The following is a description of a gene set: Individuals with 22q11.2 microdeletions show behavioral and cognitive deficits and are at high risk of developing schizophrenia. We analyzed an engineered mouse strain carrying a chromosomal deficiency spanning a segment syntenic to the human 22q11.2 locus. We uncovered a previously unknown alteration in the biogenesis of microRNAs (miRNAs) and identified a subset of brain miRNAs affected by the microdeletion. We provide evidence that the abnormal miRNA biogenesis emerges because of haploinsufficiency of the Dgcr8 gene, which encodes an RNA-binding moiety of the 'microprocessor' complex and contributes to the behavioral and neuronal deficits associated with the 22q11.2 microdeletion. from publication Stark KL, Xu B, Bagchi A, Lai WS, Liu H, Hsu R, Wan X, Pavlidis P, Mills AA, Karayiorgou M, Gogos JA (PMID 18469815) Mouse Gene Set: STARK_BRAIN_22Q11_DELETION Genes located outside the microdeletion region in 22q11 which were differentially expressed in the same manner both in hyppocampus and prefrontal cortex. species: Mus musculus, and this is the list of marker genes: Fjx1, A330023F24Rik, Snora74a, Aopep, Emc10, Slc17a7, Mir22hg, Mir9-2hg, Mirlet7b, Mirg, Trak1, Cdk5r1, Usp7, Clec16a, Zfp445, B3gat1, Bsn